The following is a description of a gene set: Dendritic cells (DCs) process and present self and foreign antigens to induce tolerance or immunity. In vitro models suggest that induction of immunity is controlled by regulating the presentation of antigen, but little is known about how DCs control antigen presentation in vivo. To examine antigen processing and presentation in vivo we specifically targeted antigens to the two major subsets of DCs using chimeric monoclonal antibodies. Unlike CD8+ DCs that express the cell surface protein CD205, CD8- DCs, which are positive for the 33D1 antigen, are specialized for presentation on MHC class II. This difference in antigen processing is intrinsic to the DC subsets and associated with increased expression of proteins associated with MHC processing. Genes down-regulated in 33D1+ spleen dendritic cells: Flt3L Melanom injected mice versus healthy controls. from publication Dudziak D, Kamphorst AO, Heidkamp GF, Buchholz VR, Trumpfheller C, Yamazaki S, Cheong C, Liu K, Lee HW, Park CG, Steinman RM, Nussenzweig MC (PMID 17204652) Human Gene Set: GSE6259_FLT3L_INDUCED_VS_WT_SPLENIC_DC_33D1_POS_DN species: Homo sapiens, and this is the list of marker genes: TUBB2B, CTSS (NCBI Gene Id 50653), CLDN25, KIF18B, RBFOX2, SHF, MACC1, CTNNB1, TSPAN33 (NCBI Gene Id 340348), CHD5, MEI1, ESCO2, ACOT2, MYLIP, METTL27, GLIS3, DISP3, NES, MUC13 (mucin 13, cell surface associated), PLIN2, IDI2, CENPI, LAT2, MOS, GATA6, RAB27A, EGR1, DKK2, CYFIP2, CCDC106, PLXNA2, CDH2, IL1R1, RCN3, DMRT3 (doublesex and mab-3 related transcription factor 3), IL12RB2, ANGPTL4, LMNB1, GRIK1, SYT8, IL36RN, TREML4, DCLK3, VILL, CMBL, PLXDC1, DUSP26, TRNP1, PRKG1, SLC25A27, SULF2, SLC22A20P, CARD11, CD44, IL7R, ZC3H12D, NPTX1, GPR176, ESRP1, MUCL1, AIRE, IL24 (NCBI Gene Id 11009), EMP1, ACY1, SLC40A1, SYNDIG1L, TMEM212, NOS3, STXBP5, CYTIP, MIR194-2, OMD, RASGEF1B, E2F7 (NCBI Gene Id 144455), TSPAN32, CCDC160, CBLB, CENPN, MROH2A, TMEM65, CCZ1, PAX8, CD36, BACH2, PCNA, SLC3A2, CNN2, MYADML2, GRIP2, TAFA2 (TAFA chemokine like family member 2), SEPTIN1, PTGR1, FANCA, TMC2, SBK1, TCN2, DTX4, SRL, TNFAIP8L3, MYH14, TIMM13, TNMD, BBS10, NXPE1, SOX12, DEGS1, BMP10, MPEG1, HGF, FBXO16, MAPKAPK3, PADI2, GIPC2, RAD51, PLCB1, PALLD, PRPH2, SNCAIP, RAD51C, DDX3Y, MAFB, TPPP3, DNM3, FLRT2, SDK1, NRCAM, SHISA9, NPW, FAM83F, DPY19L3, CYP2S1, CATSPER3, PLAU, DSG4, BLTP3B, MYO1B, ENTPD1, CD93, PACC1, ALX3, LONRF3, EGR3, PSD, NEO1, DNAJC12, DRD2, MT-ND4L, ATP8B4, THBS1, TPX2, PRKCA, GJA1, TRAPPC6A, CD81, PNMA3, MS4A1, CLCNKA, DPYSL3 (NCBI Gene Id 54406), ADRA1A, SH2B2, CFAP251 (cilia and flagella associated protein 251), UTY, KLK8